The following is a description of a gene set: studied in species Homo sapiens Human Gene Set: WEIGEL_OXIDATIVE_STRESS_BY_TBH_AND_H2O2 Oxidative stress plays a key role in aging diseases of the posterior pole of the eye such as age-related macular degeneration. The oxidative stress response of in vitro RPE cells has been studied for a small number of genes. However, a comprehensive transcriptional response has yet to be elucidated. The purpose of this study was to determine if the transcription of a common set of genes is altered by exposure of ARPE-19 cells to three major generators of oxidative stress, hydrogen peroxide (H2O2), 4-hydroxynonenal (HNE), and tert-butylhydroperoxide (tBH). As expected, a common response was observed that included genes differentially regulated by all three treatments. Of these, only one gene was upregulated, and only by one oxidant, while all other responses were downregulation. The majority of these genes fell into five functional categories: apoptosis, cell cycle regulation, cell-cell communication, signal transduction, and transcriptional regulation. Additionally, a large number of genes were differentially regulated by one oxidant only, including the majority of the conventional oxidative stress response genes present on the Clontech Human 1.2 microarray. This study raises questions regarding the generality of results that involve the use of a single oxidant and a single cell culture condition. Oxidative stress genes down-regulated in ARPE-19 cells (retinal pigmented epithelium) in response to tert-butyl hydroperoxide (tBH) and H2O2. from publication Weigel AL, Handa JT, Hjelmeland LM (PMID 12419474), and this is the list of marker genes: HSPA13, SF1, BMP4, ITGAL, CDH11, CAPN2, PPP1R8 (protein phosphatase 1 regulatory subunit 8), HDAC1, SRF (NCBI Gene Id 6722), ACTB (actin beta), VCAM1, CDK10, RB1, RPL13A, RPA1, DYNLL1, ITGB4, BAK1, QSOX1, TCEA1, MMP11, FMO1, TP53, CDC25C, CTNNA1, CDKN2B, SLC7A5, TUBA1B, RNH1, ZYX, ITGB5, HGFAC, HLA-C, SPINT2, TPP1